Given this list of marker genes Ufl1, Trim67 (NCBI Gene Id 330863, tripartite motif-containing 67), Axin2, Gsk3a, Csnk1a1, Fbxw8, Cbfa2t3, Egf, Dda1, Tgfb1i1, L3mbtl3, Rnf40, Sh3rf1, Herpud1, Rack1, Mdm2, Atg7, Hamp, Ddrgk1, E330034G19Rik, Sirt1, Smurf1, Sumo1, Kcne2, Plk1, Ecscr, Gba1, Pias1, Csnk1e, Ubqln2 (ubiquilin 2), Sumo2, Usp13, Socs4, Rnf185, Trib3, Fmr1, Wfs1, Hspbp1, Cdc20, Rnft1, Zer1, Sumo3, Il33, Agbl4, Eif2ak3, Det1, Cdk5rap3, Fbxw7, Oaz1, Psmd10, Trem2, Cop1, Psen2, Atxn3, Klhl40, Psen1, Eif2a, Tmem259, Hspa1a, Ctsc, Socs5, Plk3, Sirt2, Pabir1, Agtpbp1, Axin1, Rnft2, Aurka, Ptk2, Disc1, Ern1, Sh3rf3, Mtor, Nub1, Osbpl7, Laptm5, Atp5if1 (ATP synthase inhibitory factor subunit 1), Gabarap, Xbp1, Cav1, Traf7, Vcp, Stub1, Zyg11b, Fzr1, Tmtc3, Gsk3b, Prkn, Rnf139, Rbx1-ps, Rnf180, Hspa1b, Cdc20b, Rbx1, Pten, Sh3rf2 (NCBI Gene Id 269016), Gclc, Ube2v2, Bag2, Akt1, Bcap31, Tmx1, Nkd2, Fbxo22, Usp5, Mapk9, Paqr3, Trib2, Rad23a, Nupr1, Chfr, Bag6, Mapk8, Trf, Sgta, Ubqln1, Zfand2a, Ccdc22, Prickle1, Nop53, Csnk1d, Lrrk2, Rgn, Rchy1, Sirt6, Dab2ip, Dnajb2, Trib1, Ptk2b, Plk2, Tmem67, Clu, Dab2, Bbs7, Dvl1, here is a description of the gene set: Any process that activates or increases the frequency, rate or extent of proteolysis involved in protein catabolic process. species: Mus musculus Mouse Gene Set: GOBP_POSITIVE_REGULATION_OF_PROTEOLYSIS_INVOLVED_IN_PROTEIN_CATABOLIC_PROCESS